The following is a description of a gene set: Mouse Gene Set: GOBP_NEUROBLAST_MIGRATION species: Mus musculus The orderly movement of a neuroblast from one site to another, often during the development of a multicellular organism or multicellular structure. A neuroblast is any cell that will divide and give rise to a neuron., and this is the list of marker genes: Nfix, Six3, Ednrb, Abcc8, Atoh1, Fut10, Tnr, Pds5a, Gja1